Given this list of marker genes Pde4b, Kalrn, Gsk3b, Api5, Dusp1, Pdpk1, Ttbk2, Col27a1, Rnf19b, Grem2, Slc38a1, Hecw2, Cd300a, Orai1, Ptgdr, Chmp1b2 (NCBI Gene Id 74520), Psmc6, Ccn4, Chmp1b, Tada1, Lypd1, Sowahc, Ubxn4, Bmt2, Cenpc1, Hmgb3, Ccdc87, Clasp2, Ppip5k2, Iws1, Cfap52, Or52n4, Casp8, Tns3, Slc7a11, Polr3d, Rfx8, Smad2, Srpk2, Fam76a, Gch1, Vti1a, Rbfox2, Med17, Man1a2, Slc16a9, Ptpre (NCBI Gene Id 19267), Cbll1 (Casitas B-lineage lymphoma-like 1), Jade1, Dido1, Klf15, Bcl6, Rab1a, Cyrib, Itpr1, Zxdb, Lhfpl4, Egr1, Clspn, Cmc2, Sh2d3c, Eme1, Ppp1r9b, Tmem161b, Hs3st3b1, Krr1, Erg, Mrc1, Nbeal1, Qtrt2, Amer1, Lrrc58, Cltc, Spata13, Adarb1 (NCBI Gene Id 76716), Msl2, Ano9 (anoctamin 9), Khdc1b, Lemd3, Ugt8a, Aass, Rnf149, Cdyl2, Pde10a, Dnph1, Tsc22d1, Smoc2, Iars2, Papolg, Cfdp1, Dusp16, Trp53bp1, Klhl12, Cstf2, Egr3, Kbtbd2, Junb, Spn, Rora, Wfdc12, Mcur1, Ccdc166, Osgep, Slc17a1, Slain2, Nxt2 (nuclear transport factor 2-like export factor 2), Slc33a1, Runx1, Ranbp6, Zfp26, AI182371, Zfp446, Vcpip1, Kcne5, Strbp, Yes1, Vdac1, Clic5, Cldn12, Apobec3, Add3, Grina, Commd2, Zeb1, Trim44, Nup35, Prpf4b, Chek1, Rassf1, Npat, Cdk5r1, Gtse1, Asxl1 (ASXL transcriptional regulator 1), Ndnf, Mfsd2a, Six6, Zfp84, Kifc5b, Pes1, Smco3, Lrrtm2, Nectin3, Smndc1 (NCBI Gene Id 76479), Rnf152, Dmxl1, Homer1, Rbm44, Syap1, Dnajc13, Lmo4 (NCBI Gene Id 16911), Hsd17b12, Cers6, Ddx17, Qrfprl (NCBI Gene Id 243407), Smad5, Birc6, Zcchc2, Arl6ip6, Kcnip4, Prlr, Rasgrf2, Cd209a, Akap7 (NCBI Gene Id 54213), Dsel, Map3k4, Ino80d, Zfp1, Fkbp5, Cramp1, Cep97, Pi4k2a, Ppil4, Itga2, Zfp503, B3gnt2, B3galt2, Gxylt1 (glucoside xylosyltransferase 1), Atoh1, Abi2, Ssbp2, Vmn1r65, Rev1, Nusap1, Macir, Slc38a2, Epha5, Ids, Sp1, Lrrc2, Lhx9, Zfp354a, Fbxl17, Tmed5, Cenpi, Gpr176, Pik3ca, Fam199x, Kdsr, Onecut2, Apln, Kdm6a, Glrb, Tmprss11g (NCBI Gene Id 320454), Rbm47, Srgap1, Nek4, Prkcb, Pitpnb, Cxcl1, Plxnc1, Sox6, Phf8, Acer3 (alkaline ceramidase 3), Guf1, Tbcel, Ptprk, Golph3, Lrba, Gata3, Secisbp2l, Skil, Zfp874b (zinc finger protein 874b), Spink5, Gucy1b1, Cpsf6 (NCBI Gene Id 66698), Csrnp3, Syt16, Map3k8, Smc2, Nwd2, Ahr, Aspm, Btf3l4, Tube1, Edem3, Fhad1, Riok3, Lrrc59, Vwa5a, Pou6f2, Trub1, Rasa2, Fam91a1, Uty, Nras, Zmym5 (NCBI Gene Id 219105), Ier3, Dcaf10, Chrng, Arpc5l, Gtf2b, Rnaseh2a, Glo1 (NCBI Gene Id 71672), Itsn1, Mef2a, Rbbp6, Trhde, Hook3, Cldn8, Wtap, Igsf9b, Bsn, Ccdc103, Kat7, Ssh2, Lrat, Upp2, Sgpp2, Tmem108, Cxxc4, Adam17, Jph1, Npas2, Kif1b, Ccnb2, Apc, Otulinl, Ednra (NCBI Gene Id 14737), Klhl14, Me1, Sall1, Plag1, Unc5c, Lats1, Wdr43 (NCBI Gene Id 72515), Btaf1, Dhx15, Epb41l5, Gabrb3, Oas3, Nxpe3, Haus2, Dennd4a, Sgms1, Clxn, Kif23, Magi1, Zfp36l2, Pwwp3b (NCBI Gene Id 245631), Mosmo, Clptm1l, Dennd1b, Pfkfb2, Olfm5, Irgm2, Adam23, Smim18, Gad1, Etfbkmt, Chd2, Nhlrc1, Stxbp2, Tmem30a, Tgfbr1, Carf, Pkd2, Cts8, B3galt1 (UDP-Gal:betaGlcNAc beta 1,3-galactosyltransferase, polypeptide 1), Arpp19, Dimt1, Ndufs1, E2f6, Nup155 (nucleoporin 155), Skp2, Pde1c, Enpp4, Marchf5, Cdh7, Hlf, Smco1, Dnaja1, Psd3, Tmem26, Ctdspl2, Cnr1, Nexmif (NCBI Gene Id 97590), Mis18a, Zmat3, Cnot2, Max, Lin28b, Ccnt2, Tmem196 (NCBI Gene Id 217951), 4921524J17Rik (NCBI Gene Id 66714, RIKEN cDNA 4921524J17 gene), Zfp781b, Mc2r, Nampt (NCBI Gene Id 68683), Rufy2, Cstf3, Sepsecs (NCBI Gene Id 52242), Septin11, Pon3, Camk2d, Ubap2, Cbfb, Foxi1, Cdk12, Jmjd4, Dmrtc2, Katnbl1, Tlnrd1, Lonrf1, Pou4f1, Tpgs2, Slc17a4, Pla2g4c, Psmb1, Serpinb1b, Peak1, Zmynd8, Zfr, Rab7, Ube3a, Golga7b, Ap1g1, Eri1, Elf4 (E74 like ETS transcription factor 4), Arl14ep, Rnf38 (NCBI Gene Id 73469), Cmklr2, Pck1, Fam217a, Zfand6, Bpnt2, Rp1, Enox1, Mtmr3, Foxc1, Tmpo, Arid3b, Ube2o, Asxl2, Lhfpl2, Ndrg4, Tomm20, Gypa, Ska2, Apool, Cox16, Sval3, Zfp560, Mtx3, Ubap2l, Slc16a10, Cdh11 (cadherin 11), Gabpb2, Eea1, Cdo1, Cetn3 (NCBI Gene Id 12626), Dipk2a, Ms4a4d, Il13ra1, Pank3 (pantothenate kinase 3), Phip, Sema6a, Irf2bp2, Golim4, Gpr143, Ostm1, Ptpn2, Med14, Rnd3, Arhgap12, Rc3h2, Pou2f1, Sgk1, Tas1r3, Frs2, Gjc1, Get1, Crebrf, Srgap2, Intu, Zyg11b, Slc5a7, Cysltr1, Lurap1l, Stk25, Creb1, Trim42, Adgrg2, Wif1 (NCBI Gene Id 24117), Lman1, Bcl11b, Klf6, Mapk10, Slfn4, Unk, Atp6v1a, Shisa6, Daam1, Itpripl2, Rab27a, Shld2, Cd44, Tia1, Bclaf1, Csnk1g1, Ccpg1, Mpp7, Crem, Coa5, Mtmr9, Pspc1, Tmem132b, Ccdc169, Tyr, Phf20l1, Col17a1, Plcl2, Ralgps2, Myorg, Psmb11, Nr3c2, Nufip2, Adam21, Six4 (NCBI Gene Id 20474), Ankrd1, Itpr2, Cpeb4, Lmbr1, Serpinb1a, Prdx6, Rhoq, Dnajc14, Fgfr2, Rfx6, Spryd3, Cemip, Cacul1, Kat6a, Ms4a4c, Rps6ka3, Dhx40, Phlpp2, Jun, Rab5c (NCBI Gene Id 19345), Kif2a, Tigd5, Ccdc82, Smad4, Cmtm4, Setbp1, Slc4a7, Prkcd, Prkacb, Ltbp1, Fsd1l, Chpt1, Brwd1, Gpr65, Aicda, Cask, Rbm41, Zfp715, Chic1, Rimklb, Nup58, Cdh2, Sirt1, Rnf44, Ms4a4b, Pbrm1, Smurf2, Ylpm1, Spp1, Esyt2, Nherf4, Col25a1, Insm2, Taok1, Cntn5, Mrpl39, Ncoa1, Taf4b, Mei4 (meiotic double-stranded break formation protein 4), Avpr1b, Snx27, Rasl11a, Oip5, Nmrk1, AI597479, here is a description of the gene set: studied in species Mus musculus Genes predicted to be targets of miRBase v22 microRNA mmu_miR_466m_3p in miRDB v6.0 with MirTarget v4 prediction scores > 80 (high confidence targets). from publication Chen Y, Wang X (PMID 31504780) Mouse Gene Set: MIR_466M_3P